The following is a description of a gene set: Mouse Gene Set: GOMF_N_ACYLTRANSFERASE_ACTIVITY Catalysis of the transfer of an acyl group to a nitrogen atom on the acceptor molecule. species: Mus musculus, and this is the list of marker genes: Ing4, Nat1, Naa12, Jade2, Med24, Nat8f5, Bloc1s1, Kat6b, Acnat2, Glyat, Nat14, Nat8f6, Hat1, Pygo2, Gtf2b, Gnpnat1, Nat8f2, Acnat1, Alas2, Alas1, Cers6, Keg1, Usp22, Kat8, Tlcd3b, Nat2, Brpf3, Tmem68, Naa20, Nat8f4, Ncoa3, Nat10, Kat2a, Atat1, Meaf6, Naa80, Naa40, Nap1l2, Mcm3ap, Nmt2, Msx3, Taf10, Mettl8, Gtf3c4, Phf10, Jade1, Kat5, Nat8f1, Esco1, Naa10, Plaat5, Cers4, Naa50, Sat1, Brca2, Plaat3, Kat14, Ncoa1, Nmt1, Atf2, Taf1, Nat8f7, Glyatl3, Nags, Abhd14b, Smarce1, Nat9, Naa30, Plaat1, Kat2b, Brd1, Cers3, Cdyl, Cers2, Sat2, Naa60, Nat3, Ogt, Nat8b-ps, Baat, Nat8, Naa15, Cers5, Clock, Pla2g4e, Kat7, Satl1, Nat8l, Esco2, Oga, Aanat, Cers1, Ing3, Gm4952 (NCBI Gene Id 240549), Tgm2, Naa11, Brpf1, Crebbp, Nat8f3, Ep300, Taf9, Hgsnat, Tada2a, Kat6a, Lipt1